Given this list of marker genes CNGB3, SAG, C1QTNF5, GTF2E2, CDH3, PLK4, SLC24A1 (NCBI Gene Id 9187), RDH5, MPLKIP, SAMD7, NMNAT1, AARS1, TTC8, DRAM2, GUCY2D, CNNM4, ELOVL4, TARS1, CFHR1, RPGR, SCAPER, ALDH3A2, RAX2 (retina and anterior neural fold homeobox 2), ZFYVE26, CNGB1, NRL, CFH, FBLN5, BBS5, LZTFL1, ANO10, TNFRSF11B, PITPNM3, HTRA1 (HtrA serine peptidase 1), ERCC3, ABCA4, XYLT1 (xylosyltransferase 1), APOE, PCYT1A, ERCC2, RP1L1, HMCN1, GUCA1A, COL18A1, DHX38, HK1, CEP78, RLBP1, SH3BP2, RHO, YARS1 (tyrosyl-tRNA synthetase 1), ATF6, CFI, PROM1, NR2E3, EPG5, MAPKAPK3, SLC6A6, VWA8, CFAP418, RNF113A, AIPL1, CFHR3, ATXN7, IFT140, PAK2, LIG3, PRCD, FBLN1, RP9, PRPF31, ABCC6 (ATP binding cassette subfamily C member 6), MERTK, WDR19 (NCBI Gene Id 80203), GUCA1B, C9, RS1, RPGRIP1, PPT1, FBN2, GTF2H5, PAX2, GBA1, CP, CARS1, PRPF4, CLN3, SIX6, PRPH2, ARL2BP, GRK1, HLA-A, TRAF3IP1, SPG11, BEST1, XYLT2, SEMA4A, KCNV2, ZNF513, CST3, EFEMP1, UNC119, ASAH1, here is a description of the gene set: Macular degeneration studied in species Homo sapiens Human Gene Set: HP_MACULAR_DEGENERATION A nonspecific term denoting degeneration of the retinal pigment epithelium and/or retinal photoreceptor cells of the macula lutea.